The following is a description of a gene set: Human Gene Set: GSE5542_UNTREATED_VS_IFNG_TREATED_EPITHELIAL_CELLS_24H_UP from publication Sanda C, Weitzel P, Tsukahara T, Schaley J, Edenberg HJ, Stephens MA, McClintick JN, Blatt LM, Li L, Brodsky L, Taylor MW (PMID 16800785) Genes up-regulated in epithelial cells (24h): untreated versus IFNG. studied in species Homo sapiens Type I and type II interferons (IFNs) bind to different cell surface receptors but activate overlapping signal transduction pathways. We examined the effects of a type I IFN (IFN-acon1) and a type II iFN (IFN-g1b) on gene experession in A549 cells and demonstrate that there is a common set of genes modulated by both IFNs as well as a set of gene specifically regulated by each, reflecting the activation of different signaling pathways. In particualr, IFN-g induced many more genes of the signaling pathways, apoptosis, and cytokine interactions than did IFN-a. Even with genes induced by both IFNs there were distinctive quantitativive differences in expression. IFN-g1b plays a major role in the induction and regulation of the complement pathway. Previous work has shown a synergistic antivral and antiproliferative effect of type I and type II IFNs in cell culture and in the treament of tumors in mice. We demonstrate that a majority of genes showed and additive effect of IFN-acon1 and IFN-g1b, but a subset of gene is synergistically induced; these incluce ISG10, MX2, OAS2, and other genes known to be involved in the antiviral response, TRAIL (TNFSF10) and caspases involved in apoptosis and chemokine genes RANTES, CXCL10, and CXCL11. Greater than additive transcription of some of these genes in the presence of both IFNs was confirmed by real-time kinetic RT-PCR. Elevated induction of many of these genes may be sufficient to explain the synergistic antiviral and antitumor effects of this combination of IFNS in vivo., and this is the list of marker genes: EPS15, ZNF335, LPGAT1, RHBDF2, MAP2K3, CALHM2, VCP, TNIP3, SNX29P2, TIGIT, IL12RB1, SH2B3, SAV1, DUSP10, PPP2R5C, ALCAM, MIR24-2, CRIM1, AHNAK, ARL6IP1, PPP4R1, CAPN2, OPTN, NFATC2, CNOT6L, MYO1F, AUTS2, TRANK1, ACADVL, MC3R, RFTN1, ST8SIA1, ZEB2, F2R, MIR21, PLCB3, AIM2, TSPAN18, PDXK, FAS, PTPRM, EMB, MBOAT1, WEE1, ITPR3, KIF21A, ANXA2, APOBEC3F (NCBI Gene Id 29762), SNX33, EZR, RDH10, RXRA, PNPLA6, MVD, CLIC1, ATP6V0B, PLXND1, ZRSR2P1, GTDC1, SLFN11 (schlafen family member 11), IGSF9B, ZC3H12A, SEC14L1, SURF4, APOBEC3D, GPR183, KLRD1, LRP8, IL12RB2, UCK2, ARID5B, LLGL2, ARHGEF12, JOSD1, SRGN, SLAMF1, RBMS3, DLG3, CHN1, OASL, CDHR3, ODF2, RCBTB2, ARHGAP31, TGFBR3, OR9A4, STAT5B, GALM, TSHR, GBF1, TP53INP1, RGS2, TTYH2, PI4K2A, FADS3, SH3TC1, FOSL2, GZMK, RTL5, TOM1, ARHGAP35, TOLLIP, SPC25, TSEN54, RB1, NPFFR2, EIF3A, TOX, CCR4, PIEZO1, GABARAPL1, PLEKHD1, CACNB1, SH3BGRL3 (SH3 domain binding glutamate rich protein like 3), CACNB3, IL2RB, ACOT9, MAPKAPK2, CHST11, SESN3, LRIG1, BICD1, IL18RAP, THBS1, ZNF487, PHACTR2, TCIRG1, AKIRIN2, OGDH, SH2D2A, TNFRSF1B, MYO1C, PDE1B, MAP3K1, CACNB2, KSR1, CYB561, FTH1, CD99, SYTL3, ATXN1, MYBL1, ABR, IQGAP1, SLC1A4, WSB2, LINC02880, ACTN4, SNTB2 (NCBI Gene Id 6645), DUSP2, DNAJC1, ENTPD1, SYT11, MXD4, GLB1, PYHIN1, ACE, UST, SLFN12L, KATNAL1, ITPRIPL1, MICAL3, MPZL3, FUCA2, ARF3, NIPA1, FLVCR2, FYN, ULK1, SUSD6, CLDND1, HECTD3, MPDZ, NIPAL2, SEPTIN8, APOBEC3G, PDZD11, TENT5C, GGA2, SYNE1 (spectrin repeat containing nuclear envelope protein 1), SV2A, KIF1C, GRAMD4, CEP97, LYAR, HYOU1, SLCO3A1, STOM, HEATR9, LUZP1, NLRP3, GPR137C, TBX21, BATF (NCBI Gene Id 10538), RAPGEF1, GIT2, CAMTA1, ITGB1